Given this list of marker genes AICDA, ADAR, APOBEC3D, APOBEC1, APOBEC3A, APOBEC3H, ADAD1, ADARB2, APOBEC2, A1CF, ADAD2, APOBEC3B, ADAT2, APOBEC3F, RBM47, ADARB1, APOBEC3C, APOBEC3G, here is a description of the gene set: species: Homo sapiens Any base modification or substitution events that result in alterations in the coding potential or structural properties of RNAs as a result of changes in the base-pairing properties of the modified ribonucleoside(s). Human Gene Set: GOBP_BASE_CONVERSION_OR_SUBSTITUTION_EDITING